The following is a description of a gene set: Catalysis of the reaction: protein tyrosine phosphate + H2O = protein tyrosine + phosphate. studied in species Homo sapiens Human Gene Set: GOMF_PROTEIN_TYROSINE_PHOSPHATASE_ACTIVITY, and this is the list of marker genes: DUSP9, PTPRM, PTP4A3, DUSP5, PTPN22, PTPRF, CDC25B, PTPRK, EYA1, DUSP12, PTPN3, DUSP19, PTPN6, CDC25C, PTPN1, DUSP16, DUSP18, PTPRA (protein tyrosine phosphatase receptor type A), DUSP13B, EYA3, DUSP29, PTPN21, PTPRB, PTPN9, CDC14C, SLC39A10, DUSP14, ACP4, CD33, PGP (NCBI Gene Id 79118), PTPRH, DUSP8, PTPRR, IGFBP3, PTPN12, TNS2, ACP3, TIMM50, PTEN, PTP4A2, CDC25A, DUSP3, PTPN2, PTPN20, PTPN23, HACD2, EPM2A, DNAJC6, PTPRU, PTPRS, CDKN3, PTP4A1, MTMR7, UBASH3B, SSH3, PTPRZ1, DUSP22, PTPN5, DUSP1, EYA2, PTPN14, DUSP28, PTPRQ, PALD1, PTK2, DUSP11, PTPN13, MTMR6, PTPRE, TPTE, DUSP13A, PTPDC1, PTPN18, PTPMT1, PTPRO, SSH1, MTMR3, DUSP2, DUSP15, PTPA, MTMR4 (NCBI Gene Id 9110), PTPRT (protein tyrosine phosphatase receptor type T), PTPRJ (NCBI Gene Id 5795), PTPN7, MDP1, ACP1, EYA4, DUSP10, PTPN11, PPP2CA, CDC14B, DUSP4, PTPRD, PTPRG, DUSP6, DUSP7, PTPRC, DUSP26, PTPRN, PTPN4, SSH2, DUSP21, VCAN, CDC14A, PTPRN2, DUSP23